The following is a description of a gene set: studied in species Mus musculus Genes down-regulated in skin upon knockout of AOX4. The mouse aldehyde oxidase AOH2 (aldehyde oxidase homolog 2) is a molybdoflavoenzyme. Harderian glands are the richest source of AOH2, although the protein is detectable also in sebaceous glands, epidermis, and other keratinized epithelia. The levels of AOH2 in the Harderian gland and skin are controlled by genetic background, being maximal in CD1 and C57BL/6 and minimal in DBA/2, CBA, and 129/Sv strains. Testosterone is a negative regulator of AOH2 in Harderian glands. Purified AOH2 oxidizes retinaldehyde into retinoic acid, while it is devoid of pyridoxal-oxidizing activity. Aoh2(-/-) mice, the first aldehyde oxidase knockout animals ever generated, are viable and fertile. The data obtained for this knockout model indicate a significant role of AOH2 in the local synthesis and biodisposition of endogenous retinoids in the Harderian gland and skin. The Harderian gland's transcriptome of knockout mice demonstrates overall downregulation of direct retinoid-dependent genes as well as perturbations in pathways controlling lipid homeostasis and cellular secretion, particularly in sexually immature animals. The skin of knockout mice is characterized by thickening of the epidermis in basal conditions and after UV light exposure. This has correlates in the corresponding transcriptome, which shows enrichment and overall upregulation of genes involved in hypertrophic responses. from publication Terao M, Kurosaki M, Barzago MM, Fratelli M, Bagnati R, Bastone A, Giudice C, Scanziani E, Mancuso A, Tiveron C, Garattini E (PMID 18981221) Mouse Gene Set: TERAO_AOX4_TARGETS_SKIN_DN, and this is the list of marker genes: H1f3, Cfap70, Abcd2, Mau2 (MAU2 sister chromatid cohesion factor), Esrrg, 5530601H04Rik (NCBI Gene Id 71445), Casp12, Fkbp15, Hycc2, Zfp759, Acsl6, Klhl13, 4632415L05Rik, Rgs18, Igf1, 6030458C11Rik, H2ac24, Zfp354b, Mrnip, A330023F24Rik, Gm29246, Spmip4, Snurf, Tmem267, Uchl1, Samd5, Ddit4l (NCBI Gene Id 78637), Dmxl1